Given this list of marker genes PRDM5, DDX47, DOC2B, JRK (Jrk helix-turn-helix protein, NCBI Gene Id 8629), HSPA4 (heat shock protein family A (Hsp70) member 4), CACNG1 (NCBI Gene Id 786), DBP, ACTR1A, NPY1R, ACHE (NCBI Gene Id 43), TUBA8, MEF2A, NR1D1, MERTK, ACTA1, TCEA2, ZIC2, HGFAC, WWOX, GALK1, CCND1, CD4, FARSA, SMARCA4, LIN7B, DHX38, ANXA7, MTOR, CLIC3, LBX1, SAYSD1, CARS1, CNP, WNT8A, CRYGA, FABP7, CCN1, REG3G, NOS2, USP46, SLC4A1, ADRA2A, MYL4, SERPINH1, CAMK2G, OCA2, RAB4B, DPYSL2, LMOD2, SMTNL2, XIAP, THBS1, FSCN1, TNC, PISD, NFKB2, CD320, GRK3, CSF2, NAB2, COL17A1, CREM, ITM2A, PCK1, PTPRD, H1-6, PTPRM, TAOK3, SNCA, G6PC1, MYH6, SLC6A15, UBA7, here is a description of the gene set: studied in species Mus musculus Ageing of the brain leads to impairments in cognitive and motor skills, and is the major risk factor for several common neurological disorders such as Alzheimer disease (AD) and Parkinson disease (PD). Recent studies suggest that normal brain ageing is associated with subtle morphological and functional alterations in specific neuronal circuits, as opposed to large-scale neuronal loss. In fact, ageing of the central nervous system in diverse mammalian species shares many features, such as atrophy of pyramidal neurons, synaptic atrophy, decrease of striatal dopamine receptors, accumulation of fluorescent pigments, cytoskeletal abnormalities, and reactive astrocytes and microglia. To provide the first global analysis of brain ageing at the molecular level, we used oligonucleotide arrays representing genes to determine the gene-expression profile of the ageing neocortex and cerebellum in mice. Ageing resulted in a gene-expression profile indicative of an inflammatory response, oxidative stress and reduced neurotrophic support in both brain regions. At the transcriptional level, brain ageing in mice displays parallels with human neurodegenerative disorders. Caloric restriction, which retards the ageing process in mammals, selectively attenuated the age-associated induction of genes encoding inflammatory and stress responses. from publication Lee CK, Weindruch R, Prolla TA (PMID 10888876) Human Gene Set: LEE_AGING_CEREBELLUM_DN Downregulated in the cerebellum of aged adult mice (30-month) vs young adult (5-month)